The following is a description of a gene set: Methylation species: Homo sapiens Human Gene Set: REACTOME_METHYLATION, and this is the list of marker genes: AS3MT, COMT, NNMT, MTRR, AHCY, MAT1A, TPMT, MAT2B, MAT2A, N6AMT1, MTR, TRMT112, CYP1A2, GSTO1